The following is a description of a gene set: Human Gene Set: HP_ANAPHYLACTIC_SHOCK An acute hypersensitivity reaction due to exposure to a previously encountered antigen. species: Homo sapiens Anaphylactic shock, and this is the list of marker genes: SRSF2, STAT6, CBL, DOCK8, KIT, TET2, RUNX1, ASXL1